Given this list of marker genes Lrrc1, Ing3, Cnbp, Zic2, Sik3, Vdac2, Plxna4, Pkn2, Cacna2d2, Fam53b, here is a description of the gene set: Genes predicted to be targets of miRBase v22 microRNA mmu_miR_8096 in miRDB v6.0 with MirTarget v4 prediction scores > 80 (high confidence targets). Mouse Gene Set: MIR_8096 from publication Chen Y, Wang X (PMID 31504780) studied in species Mus musculus